The following is a description of a gene set: studied in species Homo sapiens Human Gene Set: MIR492 from publication Chen Y, Wang X (PMID 31504780) Genes predicted to be targets of miRBase v22 microRNA hsa-miR-492 in miRDB v6.0 with MirTarget v4 prediction scores > 80 (high confidence targets)., and this is the list of marker genes: SGCZ, PNPLA5, SPOPL, GPR15LG, NDUFA5, ADRA1A, MAT2A, CHRNB2, ELF5, ZCCHC17, DYRK1A, TRA2B, TTN (NCBI Gene Id 7847), TBC1D9B, UBR3, IGF1R, FAM151B, MYH9, FAM76A, GOLPH3, BUB3, PPME1, ATRN, KLC4